The following is a description of a gene set: studied in species Mus musculus The removal of phosphoric residues from peptidyl-O-phospho-L-threonine to form peptidyl-threonine. Mouse Gene Set: GOBP_PEPTIDYL_THREONINE_DEPHOSPHORYLATION, and this is the list of marker genes: Ppm1a, Dusp1, Dusp10, Dusp5, Ppm1d, Dusp18, Ppp2ca, Pdp1, Ppm1b, Ppm1f, Ppm1e, Ppm1g